Given this list of marker genes NLRP10, RORC, IL6ST, RC3H2, IL23A, MALT1, IL2, IL6, BRD2, JAK1, JAK3, LGALS1, CLEC7A, BATF, TYK2, PHB1, PRKCQ (protein kinase C theta), RC3H1, MIR21, IL12RB1, EP300, NFKBIZ, OPA1, STAT3, STAT5A, NOTCH1, RORA, SMAD7, CLEC6A, JUNB, SLAMF6, IL23R (interleukin 23 receptor), IL27RA, SOCS3, IL6R, ENTPD7, BRD4, TBX21, TRAF3IP2, CD69, JAK2, TNFSF18, ASCL2, IL17RA (interleukin 17 receptor A), IL12B, FOXP3, CARD9, LY9, NFKBID, LOXL3, EPHB2, ARID5A (AT-rich interaction domain 5A), ZC3H12A, ZBTB7B, IRF4, here is a description of the gene set: An immune response which is associated with resistance to intracellular bacteria with a key role in inflammation and tissue injury. This immune response is associated with pathological autoimmune conditions such as multiple sclerosis, arthritis and psoriasis which is typically orchestrated by the production of particular cytokines by T-helper 17 cells, most notably interleukin-17, IL-21 and IL-22. studied in species Homo sapiens Human Gene Set: GOBP_T_HELPER_17_TYPE_IMMUNE_RESPONSE